The following is a description of a gene set: species: Homo sapiens Reactome Pathway: Defective SLC4A1 causes hereditary spherocytosis type 4 (HSP4),  distal renal tubular acidosis (dRTA) and dRTA with hemolytic anemia (dRTA-HA) The proteins responsible for the exchange of Cl- with HCO3- are members of the SLC4 (1-3) and SLC26 (3, 4, 6, 7 and 9) transporter families. SLC4A1 (Band 3, AE1, anion exchanger 1) was the first bicarbonate transporter gene to be cloned and sequenced. It is ubiquitous throughout vertebrates and in humans, is the major glycoprotein present on erythrocytes and the basolateral surfaces of kidney cells. Variations in erythroid SLC4A1 determine the Diego blood group system. Mutations in the erythrocyte form of SLC4A1 can cause hereditary spherocytosis type 4 (HSP4; MIM:612653), a disorder leading to haemolytic anaemia (HA). Some mutations in SLC4A1 can cause distal (type1) renal tubular acidosis (dRTA; MIM:179800) (an inability to acidify urine) and dRTA-HA (dRTA with hemolytic anemia) (MIM:611590).<br> part of: SLC transporter disorders, and this is the list of marker genes: SLC4A1